The following is a description of a gene set: studied in species Mus musculus from publication Gerhold DL, Liu F, Jiang G, Li Z, Xu J, Lu M, Sachs JR, Bagchi A, Fridman A, Holder DJ, Doebber TW, Berger J, Elbrecht A, Moller DE, Zhang BB (PMID 12021175) PPAR gamma is an adipocyte-specific nuclear hormone receptor. Agonists of PPAR gamma, such as thiazolidinediones (TZDs), promote adipocyte differentiation and have insulin-sensitizing effects in animals and diabetic patients. Affymetrix oligonucleotide arrays representing genes were employed to profile the gene expression responses of mature 3T3-L1 adipocytes and differentiating preadipocytes to a TZD PPAR gamma agonist in vitro. The expression of genes was significantly up- or down-regulated by more than 1.5-fold during differentiation and/or by treatment with TZD, and these genes were organized into 32 clusters that demonstrated concerted changes in expression of genes controlling cell growth or lipid metabolism. Quantitative PCR was employed to further characterize gene expression and led to the identification of beta-catenin as a new PPAR gamma target gene. Both mRNA and protein levels for beta-catenin were down-regulated in 3T3-L1 adipocytes compared with fibroblasts and were further decreased by treatment of adipocytes with PPAR gamma agonists. Treatment of db/db mice with a PPAR gamma agonist also resulted in reduction of beta-catenin mRNA levels in adipose tissue. These results suggest that beta-catenin plays an important role in the regulation of adipogenesis. Thus, the transcriptional patterns revealed in this study further the understanding of adipogenesis process and the function of PPAR gamma activation. Selected genes down-regulated during differentiation of 3T3-L1 cells (fibroblast) into adipocytes in response to adipogenic hormones. Mouse Gene Set: GERHOLD_ADIPOGENESIS_DN, and this is the list of marker genes: Sae1, Gas7, Anxa2, Thbd, Fn1, Mmp14, Ubtf (NCBI Gene Id 78596, upstream binding transcription factor, RNA polymerase I), Thbs2, Hgfac, Cryab (crystallin, alpha B), Itgb1, Cct2, Vcan, Samhd1, Cdk4, Ccnd2, Gas1 (growth arrest specific 1), Pdcd2, Hspa8, Xdh, Ccnd1, Gas6, Eif3c, Plat, Il1r1, Bid, Zfp148, Ccn1, Thbs1, Cd81, Il11ra2, Ccn2, Dnajb1 (DnaJ heat shock protein family (Hsp40) member B1), Atf1, Ecm1, Cd9, Akr1b1, Tubb5, Il4ra, Eef2, Pdgfrb, Sox4, Tnfaip2, Cdc37, Ccl7, Ifrd1, Cxcl12, Anxa3, Bax (NCBI Gene Id 12028), Cct5 (NCBI Gene Id 12465), Anxa5, Vdr, Ucp2, Ddb1, G0s2, Ccl2, Tuba1a, Sdc1, Ier3, Fgf7, Cebpd, Cd44, Casp8